Given this list of marker genes WNT11, WNT5A, WNT7A, SMAD4, TBX1, TGFB2, TGFB3, TGFBR3, FOXE1, MMP25, TSHZ1, TGFBR2, FZD1, GABRB3, SMAD2, WNT3A, FZD2, ITGB6, CHD7, JAG2, SOX11, LEF1, WNT8A (Wnt family member 8A), LRRC32, DLG1, COL11A2, ITGB8, here is a description of the gene set: The biological process whose specific outcome is the progression of the secondary palate from an initial condition to its mature state. This process begins with the formation of the structure and ends with the mature structure. The secondary palate is the part of the palate formed from the fusion of the two palatine shelves, extensions of the maxillary prominences. species: Homo sapiens Human Gene Set: GOBP_SECONDARY_PALATE_DEVELOPMENT